Given this list of marker genes POLR2D, ERCC3, SKIC8, SUPT6H, GTF2H4, POLR2E, TAF1, ELOB, TAF7L, TAF11, MLLT1, SUPT5H, CTDP1 (NCBI Gene Id 9150), PAF1, NCBP2, TAF9, POLR2K, GTF2A2, POLR2F, POLR2H, POLR2A, TAF1L, GTF2E2 (general transcription factor IIE subunit 2), GTF2F2, POLR2I, ELOA2, CDK7, CCNT2, CCNT1, GTF2H3, NELFE, POLR2J, TAF3, ELOC, NCBP1, MLLT3, TAF13, GTF2E1, SSRP1 (structure specific recognition protein 1), CDC73, AFF4, GTF2F1, ELOA, GTF2H1, SUPT16H, TAF4B, TAF2, CCNH, EAF2, GTF2H5, POLR2G, TAF5, GTF2B, GTF2H2, GTF2A1, TBP, SUPT4H1, TAF6, TAF7, MNAT1, EAF1, TAF4, CTR9, TAF15, POLR2C, POLR2L, TCEA1, TAF12, ERCC2, CCNK, NELFA, TAF9B, CDK9, POLR2B, TAF10, ELL, IWS1, RTF1, NELFCD, NELFB, LEO1, here is a description of the gene set: Human Gene Set: REACTOME_RNA_POLYMERASE_II_PRE_TRANSCRIPTION_EVENTS studied in species Homo sapiens RNA Polymerase II Pre-transcription Events